Given this list of marker genes LPAR2 (lysophosphatidic acid receptor 2), CELA2B, GTF3C1, ADAM19, NRCAM, GOLGA2, ASTN2 (NCBI Gene Id 23245), CNOT9, DZIP3, PIPOX (NCBI Gene Id 51268), AKTIP, NKAIN1, ZFYVE16, TSPAN3, ARRB1, VWA5A, PDZRN3, CDH3, MTUS2, TFAP2B, ADRA2A, PGBD5, RASSF4 (NCBI Gene Id 83937), POLG2, ABAT, FOXF1, BMERB1, MYCN, JAKMIP2 (NCBI Gene Id 9832), NELL1, CNR1, CEP104, ATP6V0A4, POU4F1, ADAM10, SGMS1, DISC1, ARHGAP26, FGFR2, MACROH2A2, PKP1, UBXN4, LRRFIP2, MYO1E, ARHGAP25, IL4R, BMP5 (NCBI Gene Id 653), ZNF330, IQCG, here is a description of the gene set: Genes down-regulated in Rh4 cells (alveolar rhabdomyosarcoma, ARMS) after knockdown of the PAX3-FOXO1 fusion protein by RNAi for 72 hr. from publication Ebauer M, Wachtel M, Niggli FK, Schäfer BW (PMID 17525748) species: Homo sapiens The chromosomal translocation t(2;13), characteristic for the aggressive childhood cancer alveolar rhabdomyosarcoma (aRMS), generates the chimeric transcription factor PAX3/FKHR with a well known oncogenic role. However, the molecular mechanisms mediating essential pathophysiological functions remain poorly defined. Here, we used comparative expression profiling of PAX3/FKHR silencing in vitro and PAX3/FKHR-specific gene signatures in vivo to identify physiologically important target genes. Hereby, 51 activated genes, both novel and known, were identified. We also found repression of skeletal muscle-specific genes suggesting that PAX3/FKHR blocks further differentiation of aRMS cells. Importantly, TFAP2B was validated as direct target gene mediating the anti-apoptotic function of PAX3/FKHR. Hence, we developed a pathophysiologically relevant transcriptional profile of PAX3/FKHR and identified a critical target gene for aRMS development. Human Gene Set: EBAUER_TARGETS_OF_PAX3_FOXO1_FUSION_DN